The following is a description of a gene set: studied in species Mus musculus The series of molecular signals in which a signal is conveyed from the cell surface to trigger the apoptotic death of a cell. The pathway starts with either a ligand binding to a cell surface receptor, or a ligand being withdrawn from a cell surface receptor (e.g. in the case of signaling by dependence receptors), and ends when the execution phase of apoptosis is triggered. Mouse Gene Set: GOBP_EXTRINSIC_APOPTOTIC_SIGNALING_PATHWAY, and this is the list of marker genes: Gclc, Zdhhc3, Itga6, Gclm, Dedd2, Gstp2, Bloc1s2, Bax, Tnfrsf22, Rbck1, Ifng, Cd27, Faim2, Zswim2, Bcl2l11, Atf3, Cav1 (caveolin 1, caveolae protein), Pak2 (NCBI Gene Id 77101), Agt, Ddx47, Gdnf, Eya4, Fcmr, Gata1, Hspa1b, Il4, Itgav, Grina, Krt8, Itm2c, Psen2, Nol3, Park7, Eya3, Madd, Jak2, Fyn, Bcl2a1a, Dapk3, Tnfsf12, Itprip, Faim, Hyal2, Ctnna1, Bad, Daxx, Lmna, Sp100, Tnfrsf10b, Fgb, Smad3, Bcl10, Casp8, Ar, Tnfrsf12a, Krt18, Fgg, Bcl2a1d, Csf2, Dedd, Sort1, Foxo3, Htra2, Gstp1, Spi1, Clca3a2, Tnfsf14, Yap1, Acsl5, Fgfr2, Mllt11, G0s2 (NCBI Gene Id 98617), Pml, Gabarap, Gsdma3, Tlr3, Casp2 (NCBI Gene Id 12366), Tgfbr1, Map2k5, Bmpr1b, Tradd, Lcn2, Dapk1, Ltb, Ndufa13, Tlr6, Pak5, Fem1b, P2rx7, Fgfr3, Trps1, Fasl, Brca1, Il2, Ddx3x, Zfp110, Mcl1, Snai2, Tmbim1, Fgf10, Faf1, Gstp-ps, Rnf41, Unc5b, Pmaip1, Phip, Hmox1, Deptor, Rps6kb1, Bcl2l2, Sfrp2 (NCBI Gene Id 99743), Dbh, Gstp3, Tnfaip3, Il19, Tnfsf10, Pdia3, Tlr4, Stk3, Siglec1, Tnfrsf23, Ptprc, Bmp4, Peli3, Erbb3, Src, Pycard (NCBI Gene Id 66824), Agtr2, Tnfsf11 (NCBI Gene Id 21943), Mknk1, Fgfr1, Eya1, Fga, Il3, Nfkbiz, Icam1, Casp8ap2, Rffl, Gfral, Acvr1b, Pdpk1 (NCBI Gene Id 18607), Sfrp1, Ret, Parp2, Rnf34, Cd40lg, Tnf, Tnfrsf1a, Pea15a, Gsk3a, Jak3, Thbs1, Ppp1ca, Il1b, Sgpp1, Tnfrsf1b, Eya2, Nrp1, Skil, Dab2ip, Bcl2l10, Stk4, Fadd, Tgfb1, Mal, Dab2, Acvr1, Bid, Nf1, Il33, Hipk1, Bcl2l14, Tert, Serpine1, Pidd1, Htt, Dele1, Cttn, Siah2, Ngfr, Tgfb2, Bcl2 (NCBI Gene Id 98734), Cd70, Cflar, Hmgb2, Scg2, Bak1, Wwox, Ltbr, Bag3, Il1a, Tmc8, Ppp2r1b, Raf1, App, Vegfa, Nrg1, Rb1cc1, Bcl2l1, Gpx1, Mknk2, Fas, Bok, Traf1, Lgals3, Agap2, Ppp2r1a, Gsk3b, Ripk1, Tnfsf15, Traf2, Il12a, Hgf, Il7, Sh3rf1, Col2a1, Rock2, Bcl2a1b, Gas1, Prdx2, Moap1, Birc6, Bex3, Bcl2a1c, Srpx, Zmynd11, Lta, Igf1, Pik3r1, Cx3cl1, D1Pas1, Psme3, Tcf7l2, Smad4, Inhba, Siva1, Ngf, Gper1, Cyld, Tnfrsf4, Tnfsf4, Rela (v-rel reticuloendotheliosis viral oncogene homolog A (avian)), Stradb, Runx3, Klf4, Il18, Kitl, Mapk7, Stx4a, Sgk3, Faiml